The following is a description of a gene set: from publication Chen Y, Wang X (PMID 31504780) Human Gene Set: MIR4715_5P species: Homo sapiens Genes predicted to be targets of miRBase v22 microRNA hsa-miR-4715-5p in miRDB v6.0 with MirTarget v4 prediction scores > 80 (high confidence targets)., and this is the list of marker genes: MRTFB, MIER1 (MIER1 transcriptional regulator), DYRK1A, SLCO4C1, RAC1, INTS5, PLPPR4, NEUROD4, UCK2, PHKB, ZNF544, MYEF2, LARP1, TRIQK (triple QxxK/R motif containing), RDH10, PANK1, NCAM1, RC3H1, PIK3R3, SERINC4, HOMER1, TMEM52B, ARHGAP19, DCUN1D4, CNN3, GJB2, HMGCLL1, TEX2, CTXN3, CCN4, PPP1R10, EXTL2, UBE2G1, SULT1C3, ATRNL1, TUSC1, HDC, ARHGEF12, MXD3, SEPTIN9, RHOA, STMN2, EXT1